The following is a description of a gene set: Reactome Pathway: rRNA modification in the nucleus and cytosol Human ribosomal RNAs (rRNAs) contain about 200 residues that are enzymatically modified after transcription in the nucleolus. The modified residues occur in regions of the rRNAs that are located in functionally important parts of the ribosome, notably in the A and P peptidyl transfer sites, the polypeptide exit tunnel, and intersubunit contacts. The two most common modifications are pseudouridines and 2'-O-methylribonucleotides. Formation of pseudouridine from encoded uridine is catalyzed by box H/ACA small nucleolar ribonucleoprotein (snoRNP) complexes and methylation of the hydroxyl group of the 2' carbon is catalyzed by box C/D snoRNPs. The snoRNP complexes contain common sets of protein subunits and unique snoRNAs that guide each complex to its target nucleotide of the rRNA by base-pairing between the snoRNA and the rRNA. Other modifications of rRNA include 5-methylcytidine, 1-methylpseudouridine, 7-methylguanosine, 6-dimethyladenosine, and 4-acetylcytidine. In yeast most modifications are introduced co-transcriptionally, however the order of modification events and pre-rRNA cleavage events is not well characterized. part of: rRNA processing in the nucleus and cytosol species: Homo sapiens, and this is the list of marker genes: UTP3, UTP25, KRR1, NOP56, HEATR1, DKC1, TSR3, DIMT1, BUD23, RPS7, DCAF13, WDR3, PWP2, PNO1, UTP6, DHX37, DDX47, RRP9, 28S rRNA, NOP14, NOL11, NOL6 (nucleolar protein 6), FCF1, BMS1, RNA45S5, NHP2, SNORD3A, WDR36, UTP14C, NOP58, UTP18, GAR1, RPS6, PDCD11, UTP14A, DDX49, RPS2, DDX52, UTP4, MPHOSPH10, UTP11, UTP20 (UTP20 small subunit processome component), RRP7A, UTP15, NOP2, RRP36, IMP3, RPS9, NOC4L, RCL1, WDR43, NOP10, SNU13, NAT10 (N-acetyltransferase 10), IMP4, EMG1, RPS14, FBL, THUMPD1 (THUMP domain containing 1), TRMT112, TBL3, WDR75, WDR46